The following is a description of a gene set: studied in species Mus musculus Mouse Gene Set: GOBP_RESPONSE_TO_GROWTH_FACTOR Any process that results in a change in state or activity of a cell or an organism (in terms of movement, secretion, enzyme production, gene expression, etc.) as a result of a growth factor stimulus., and this is the list of marker genes: Amhr2, Wnt1 (NCBI Gene Id 22408), Numa1, Gdf10, Ptpn11, Tmem204, Hsp90ab1 (heat shock protein 90 alpha (cytosolic), class B member 1), Onecut1, Vegfb, Gstp1, Kdr, Nfia (nuclear factor I/A), Suds3, Fermt1, Acvr2a (activin receptor IIA), Pelo, Ing1, Epha4, Phox2b, Spint1, Fgfrl1, Trp53, Fgf10, Shc1, Wfikkn1, Fst, Insrr, Hivep1, Htra2, Ndst1, Smad1, Epha8, Ret, Map3k7 (mitogen-activated protein kinase kinase kinase 7), Cad, Kcnc2, Gpc3, Gdf2, Ehd4, Nfkbiz, Tnfaip6, Tgfb1, Sfrp4, Mtss2, Fstl3, Cd109, Cstf2, Mt3, Myog (NCBI Gene Id 17928), Rgma, Fgf6, Stk11, Shisa2, Vegfd, Ppm1a, Sfrp1, Epn2, Tmem100, Pin1rt1, Hes5, Ryr1, Ehd1, Ntf3, Wnt5a, Ecsit, Map3k1, Fermt2, Fgf9, Tcf4, Heyl, Scx, Epha7, Acvrl1, Csf1r, Mir155, Rela, Ltk, Apln, Megf8, Ptprk, Brms1l, Vasn, Sox9, Cdc5lrt1, Tfap2b, Ephb2, Gpr155, Lef1, Trpv1, Cdc5lrt4, Fgfbp3, Gata4, Dync1li1, Crim1, Snx25, Rapgef1, Il6, Lhx1, Myocd, Spry2, Sh3glb1, Ephb4, Ptk2, Dnm2, Acap2, Postn, Dbn1, Dnmt1, Twist1, Smad2, Mir145a (NCBI Gene Id 387163), Vegfc, Ldlrad4, Dlx1, Scube3, Fkbp8, Elapor2, Msx1, Has2, Zdhhc17, Fzd4, Adissp, Epha5, Pparg, Prkd1, Il4, Hspb1, Bmp4 (NCBI Gene Id 12159), Pdpk1, Cdkn2b, Men1 (multiple endocrine neoplasia 1), Arap1, Itga5, Ext1, Lats1, Rgmb, Lats2, Wnt10a, Cav2, Cd44, Snw1, Ppara, Wnt3a, Stat3, Veph1, Lgals9, Zfhx3, Met, Uri1, Epha2, Itgb3, Acta2, Baiap2 (NCBI Gene Id 97767, brain-specific angiogenesis inhibitor 1-associated protein 2), Twf2, Mef2c, Smpd3, Tek, Brms1, Mir125a, Cask, Grb10, Sap130, Ofd1, Nog, Gipc1, Zbtb7a, Zfyve27, Rbpms2, Nrp1, Ogt, Dcp1a, Ddit3, Ddx5, Smad3 (NCBI Gene Id 17127), Atf2 (NCBI Gene Id 97033), Dll4, Bmncr, Pdcd5 (NCBI Gene Id 98188), Rab14, Ntrk2, Flrt2, Frs2, Lrrc25, Angpt2, Hif1a, Ddit4, Mir21a, Trim33, Pak2 (p21 (RAC1) activated kinase 2), Vwc2, Tgfbr2, Ppp1r9b, Calca, Lrp2, Htra1 (HtrA serine peptidase 1), Chrdl2 (chordin-like 2), Cidea, Chst11, Cd63, Appl1, Tmem119, Casp3, Syap1, Kcp, Fgf14, Map2k3, Dusp3, Egfr (epidermal growth factor receptor), Itga8, Fgf4, Fgf21, Tnc, Agt, Nus1, Smad6, Nkx2-1 (NK2 homeobox 1), Ascl1, Hspa5, Emd, Eef2k, Pdcd6, Foxd1, Ltbp3, Grem1 (NCBI Gene Id 23892), Adamts7, Tmem108, Fndc4, Notch1, Akt1s1, Fgf3, Fam83g (family with sequence similarity 83, member G), Glg1, Dab2, Ddr1, Zeb1, Rapgef2, Rock2, Cited2, Elk1, Cflar, Nrros, Edn1, Star (NCBI Gene Id 52131), Ephb1, Sort1, Myof, Tsc22d1, Fuz, Trim71, Bag4, Dok5, Kdm5b, Bmpr2, Ppp2r5b, Dlx3, Epha10, Mir329, Comp, Cdc5lrt7, Ngfr, Smad4, Nlk, Tgfb1i1, Zfp423, Flt1, Snx6, Fbxl15, Nrep, Plcg1, Grb2, Pdgfra, Shcbp1, Rnf111, Mmrn2, Il17f, Anxa1, Itgb6, Neo1, Bmpr1a, Parp1, Has1, Ltbp1, Sostdc1, Rbpj (NCBI Gene Id 791349), Smurf1, Cilp, Lmtk2, Git1, Sema6a, Pbld1, Prmt1, Lrp1, Map2k5 (NCBI Gene Id 23938), Spred2, Fgfr2, Dcstamp, Npnt, Mstn, Sh3gl2, Cib1, Mir143, Cldn5, Dlx5, Apaf1, Mir138-1, Itgb1, Ndp (Norrie disease (pseudoglioma) (human)), Foxo3, Erfe, Kl, Ireb2, Cxcl13, Dand5, Rack1, Axin1, Igf1r, Ndn, Cdh3, Churc1, Tspan32, Wnt7a, E2f1 (NCBI Gene Id 13555), Crk, Gcnt2, Jcad, Mir103-2 (microRNA 103-2), Tab1, Cat, Pax9, Flcn, Ube3a, Sulf2, Ltbp4, Prdm14, Col4a2, Tgfb3, Tac1 (tachykinin 1), Itga3 (NCBI Gene Id 16400), Fstl5, Fgf7, Tgfb2, Hgf, Folr1, Smad5, Epha3 (Eph receptor A3), Ier2, Hhex, Scgb1a1, Zpr1, Strap, Med1, Bcar1, Col1a2, Bmp10, Il12a, Gdf15, Lrg1, Usp9x, Fos, Csnk1e, Grk2, Runx3, Slit2, Fgf22, Bmper, Mir147, Cbl, Mst1r, Mapk1, Cdkn1c, Itgb8, Cps1, Sap30l (SAP30-like), Hpgd, Ror2, Kdm6a, Sap30, Fgf1, Bmp8a, Fat4, Cdc5lrt5, Twsg1, Runx2, Cx3cr1, Ark2c, Notch2, Zfp451, Plk5, Onecut2, Tgfbr3l, Smad7, Mirlet7f-1, Kcnc1 (NCBI Gene Id 320399), Ptp4a3, Fam89b, Sfrp2, Rps3, Fgf12, Magi2, Cdc5lrt10, Atp7a, Creb3l1, Stub1, Musk, Bambi, P2ry1, Acvr1, Ctsk, Lpxn, Gria1, Cldn1, Eid2, Fgfr3, Nfix, Sost, Rps6kb1, Spred1, Spry4, Usp8, Mars1, Gdf3, Spart, Ctnnb1, Dusp6, Yes1, Bmp6, Adam17, Mirlet7d, Bglap, Cyfip1, Adam9, Gfra1, Jun, Hdac6, Enpp1, Cav3, Gata3, Ing2, Mirlet7f-2, Cripto, Smad9, Eef1a1 (NCBI Gene Id 13627), Mir192, Thbs1 (thrombospondin 1), Coro1b, Col2a1, Fstl4, Rhod (NCBI Gene Id 11854), Zdhhc16, Hoxa13, Furin, Mir122, Adamts3, Ext2, Lemd3, Cdc5l, Erbb4, Klb, Mdm2, Vegfa, Cdc5lrt9, Rab35, Akt1 (NCBI Gene Id 268604), Ephb3, Mir338, Tnrc6c, Kidins220, Col3a1, Epha1, Adgrg1, Inpp5k, Cd2ap, Erbb2 (NCBI Gene Id 13866), Pin1, Slc2a10, Fasl, Stk16, Zeb2, Ros1, Tpr, Tbx20, Hipk2, Dtymk, Hyal1, Serpine1, Pdgfrb, Bloc1s6, Mir23a, Nodal, Cd59a, Sirt1, Smurf2, Cited1 (Cbp/p300-interacting transactivator with Glu/Asp-rich carboxy-terminal domain 1), Cdc5lrt8, Fgfbp1, Tmem53, Dync1li2, Rap1gap, Cpne3, Pde8a, Mir219a-2, Fgf5, Lrit3, Dsg4, Becn1 (NCBI Gene Id 56208), Egr1, Snai2, Tbx2, Hes1, Snx1, Flt4, Sparc (secreted acidic cysteine rich glycoprotein), Dmd, Skil, Spred3, Zfp36, Cdc5lrt6, Nos3, Frs3, Wasf1, Tbc1d7, Bmpr1b, Nbl1, Gab1, Nr3c1, Prkce, Mir16-1, Pdcd5-ps, Sin3a, Creb1 (NCBI Gene Id 98624), Slc4a7, Fkbp1a, Flrt3, Adamts12, Gata6, Arid4b, Bmp5, Id1, Pdgfd, Lrp8, Agtr2, Gria2, Kif16b, Usp15, Sdcbp, Ep300, Mirlet7b, Zyx, Rbbp4, Cdh5, Tob1, Arf6 (NCBI Gene Id 11845), Zfyve9, Fgf20, Myo1c, Tbx1, Runx1, Fgf17, Pxn, Braf, Ndnf, Gas6, Cyfip2, Pdcd4, Grip1, Chrd, Abl1, Ptprf, Pde3a, Casr, Slc39a5, Pik3ca, Sinhcaf, Pdgfb, Rock1, Fgfr1, Kat2a, Mertk, Bmp2, Actr3, Gdf6, Ramp2, Ntf5, Gclc, Dusp22, Appl2, Pbld2, Zfp703, Ski, Tcf7l2, Mapk14, Stmn2, Rap1a, Xcl1, Dstyk, Cer1, Mir210, Vwc2l, Fut8, Ptpn1, Nptn, Zfp128, Flrt1, Lrrc32, Arid4a, Alk, Mir181d, Cav1 (NCBI Gene Id 12389), Iqgap1, Crb2, Skor1, Alpi, Tlr4, Fgf8, Ero1a, Spry1, Il12b, Epb41l5, Elavl4, Tet1, Got1, Hdac2, Eng, Epha6, Fgf18, Bmp8b, Mirlet7a-1, Penk, Stat5b, Acvr2b, Ccl5, Tmprss6, Mapk3, Cblc, Cadm4, Atp2b4 (NCBI Gene Id 381290), Ncl (nucleolin), Ern1, Klf4, Il10, Zfp36l2, Fgf2, Src, Selenon, Nfkb1, Mir675, Gad2, Bex1, Ngly1, Mapkapk2 (NCBI Gene Id 98242), Adamtsl2, Ankrd1, Itgb1bp1, Ccbe1, Sox11 (SRY (sex determining region Y)-box 11, NCBI Gene Id 67779), Nepn, Mir145b, Fez1, Gsk3b, Fgfr4, Prkcb, Raf1, Fshb, Oprd1, Dlg1 (discs large MAGUK scaffold protein 1), Grem2 (gremlin 2, DAN family BMP antagonist), Ilk, Hap1, Garem1, Nrxn1, Xbp1, Bmp7, Spg21, Fam20c (NCBI Gene Id 97210), Lox, Lgmn, Pitx3, Spon2, Nr4a1, Robo1, Egr3, Chrdl1, Hdac1, Ngf, Gdf5, Tgfbr3, Dab2ip, Mtmr4, Insr, Bdnf, Sulf1, Skor2, Shoc2, Tnfrsf1b, Ppargc1a, Ptpn12, Htra3, Ntrk3, Bcl9l, Wnt2, Hfe, Pmepa1, Rasl11b, Ccna2, Acvr1b, Ulk1, Hgs, Ntrk1, Kit, Fyn, Gdnf, Mmrn1, Hrg, Smoc2, Arrb2, Zmiz1, Aspn, Nos1, Ints9, Fgf15, Mapk7, Cep57, Prkd2 (NCBI Gene Id 232912), Nanog, Emilin1, Pgf, Xdh, Acvr1c, Coro1a, Meis2, Tyro3, Foxc1, Prdm16, Pik3cd, Hhip, Kcnd3, Dkk1, Knstrn, Fer, Flt3, Fstl1, Mir219a-1, Mir138-2 (microRNA 138-2), Ovol2, Zcchc12 (NCBI Gene Id 72693), Pax6, Sphk1, Gclm (NCBI Gene Id 99692), Sox5, Ccn2, Ppp2r5d, Nedd4, Etv2, Vil1, Gpc1, Map1b, Crebbp, Itgb5, Ddr2 (discoidin domain receptor family, member 2), Ibsp, Peg10, Vsir, Wfikkn2, Rbbp7, Msx2, Anxa3, Gata5, Pik3cb, Vtn, Fbn1, Mir26b, Hjv, Foxh1, Ccn1, Pml, Zfp36l1, Nrp2, Cfl1, Tie1, Axl, Angpt1, Pals1, Hyal2, Sos1, Mcm7, Gdf7, Rasa1, Lemd2, Dcn, Crkl, Fgf16, Akr1c18, Vstm2a, Ripk1, Dll1, Ctdspl2, Wnt4, Sorl1, Th, Ptprd, Arpc2, Ccl2 (C-C motif chemokine ligand 2), Sox6, Ift80, Spi1, Cnmd, Slc9a6, Mir103-1, Fbn2, Npr2, Fgf23, Col1a1, Il17rd, Micall1, Fzd1, Ube2o, Hif1an, Wwox, Adgra2, Sox2, Tgfbr1, Kmt2a